Given this list of marker genes Pink1, Huwe1 (HECT, UBA and WWE domain containing 1), Hdac6, Prkn, Tomm7, Atp5if1, Hk2, Cdc37, Vdac1, Gba1, Mul1, here is a description of the gene set: Any process that activates or increases the frequency, rate or extent of type 2 mitophagy. species: Mus musculus Mouse Gene Set: GOBP_POSITIVE_REGULATION_OF_TYPE_2_MITOPHAGY